Given this list of marker genes Fxyd1, Fxyd6, Fxyd2, Fxyd7, Fxyd5, Atp1b2, Fxyd4, Atp1b3 (ATPase, Na+/K+ transporting, beta 3 polypeptide), Atp1b1, Fxyd3, Agrn, here is a description of the gene set: Any process that modulates the frequency, rate or extent of sodium ion export across the plasma membrane. Mouse Gene Set: GOBP_REGULATION_OF_SODIUM_ION_EXPORT_ACROSS_PLASMA_MEMBRANE species: Mus musculus